Given this list of marker genes SEC31A, PIGR, GCFC2, NTPCR, HTR4, HTR7, GPATCH8, SLC2A1, DPT, PIK3CB, TNFRSF25, MARCHF6, IMPA1, ZNF500, ZNF592, CYP11A1, LPGAT1, NKRF, RBBP8, COX6A2, CSTF3, PDXDC1, PAXIP1, TMCC1, FNTB, MSL3, CETN3, TBX5, POLA1, ZNF133, LTN1, SPRED2, SS18, LTBP4, ATP6V0A2, CDK13, MC2R, JRK, KIAA0586, GSK3B, RAP1A, RUNX1, UBR2, MLN, SEZ6L, TMEM94, NRTN, INPP5E, SLC30A3, HNRNPL, SNX4, FDXR, SMG1, CMA1, NFRKB, SLC16A5, MC5R, PIGF, CPSF4, ADH5 (NCBI Gene Id 2223), PHF21A, RFC5, BTD, TTI1, AQP5, TTLL5, CALCOCO1, ENTREP1, GTSE1, ECE2, MRE11, PIGB, TRIM27, SPAST, SSTR5, MIA2, KLHDC10, NSL1, SH2B1, YAF2 (YY1 associated factor 2), PEX3, SLC4A3, PIK3C2A, BRD1, NEK9, ST13, SYNJ2, SLC6A11, IGBP1, CEP135, ATRX, SPEF1, DIMT1, KAT8, RB1, TBCE, C1orf216, TCF12, ARHGAP12, PIAS2, PAFAH1B1, BPHL, POP4 (NCBI Gene Id 10775), BCL2, CHD3, PCF11, KLHL20, KAZN, GOLGA3, SULT2B1, CDYL, IPCEF1, NFX1, PAX9, IL13, UBE4B, DOK1, CLPX, ERCC2, FANCG, MFN1, EIF5B, MGA, ADCY3, ITIH4, PRELID3A, TAF2, KLHL18, PHF10, SEC62, MUTYH, SLC25A11, PPIL2, BRCA1, FRYL, PARN, POU6F2, AGPS, TAF5L, PLEKHB1, LEPROTL1, FOSL1, MSX1, KRT33A, ZNF292, AMFR, SCAMP1, VAMP4, CYP4F12, COLQ (collagen like tail subunit of asymmetric acetylcholinesterase), BAHD1, UTRN (NCBI Gene Id 7402), KANK2, MTX1, NCKIPSD, RNF14, SMC5, MICAL3, RASSF1, IKBKE, NFYB, SIK3, GRIP2 (glutamate receptor interacting protein 2), KANK3, PPP1R3D, DNAJC16, CHD9, ZNF271P, DNA2, NR2C1, PCGF1, PSMF1, REV3L, WIPF2, ERC1, FAM8A1, EXTL3, CAMK2G, MT4, CLP1, GRIK5, GLE1, LSM1, WDR62, TPR, TLN2, RERE, DTNA, CLOCK, HOXD4, POLR2K, NR3C1, AIMP1, TMEM11, KDM3B, CACNB2, PPP5C, TBC1D22A, NMT1, IRF2, GPR15 (G protein-coupled receptor 15), ZNF32, ZBTB22, ESR1, MSH3, OARD1, SLC24A1, FIG4, RPS6KB2 (NCBI Gene Id 9017), CEP350, RSRP1, KRT86, EP400, NUMB, INSIG2, here is a description of the gene set: Neighborhood of ATRX alpha thalassemia/mental retardation syndrome X-linked (RAD54 homolog, S. cerevisiae) in the MORF expression compendium studied in species Homo sapiens Neighborhood of ATRX Human Gene Set: MORF_ATRX